The following is a description of a gene set: The process in which the anatomical structures of the middle ear are generated and organized. The middle ear is the air-filled cavity within the skull of vertebrates that lies between the outer ear and the inner ear. It is linked to the pharynx (and therefore to outside air) via the Eustachian tube and in mammals contains the three ear ossicles, which transmit auditory vibrations from the outer ear (via the tympanum) to the inner ear (via the oval window). Mouse Gene Set: GOBP_MIDDLE_EAR_MORPHOGENESIS studied in species Mus musculus, and this is the list of marker genes: Osr1, Insig2, Gsc, Eya1, Msx1, Naglu, Enpp1, Eya4 (NCBI Gene Id 319558), Tshz1, Rpl38, Prrx2, Myc, Six2, Insig1, Fgfr1, Nkx3-2, Edn1, Tbx1, Prkra, Gas1, Nog, Six1, Osr2 (odd-skipped related 2), Hoxa2, Ednra, Prrx1